The following is a description of a gene set: Genes predicted to be targets of miRBase v22 microRNA mmu_miR_129b_5p in miRDB v6.0 with MirTarget v4 prediction scores > 80 (high confidence targets). studied in species Mus musculus Mouse Gene Set: MIR_129B_5P from publication Chen Y, Wang X (PMID 31504780), and this is the list of marker genes: Acbd3, Frk, Pou2f2, Zfhx3, Ttc28, Gabrb2, Wnt3, Brpf1, Tfap2b, Bzw1, Megf9, Ctxn3, Vgll3, Med14, Tmem33, Nr2f6 (nuclear receptor subfamily 2, group F, member 6), Tmem158, Ephb1, Smarca4, Adipor2, Prdm16, Rab14, Lcorl, Pimreg, Zeb2, Onecut2, Arhgef9, Yipf4, Aak1, Maml1, Map2, Cxxc5, Myrip, Smad7, Hao2, Nhlh2, Mycl, G6pc1, Ppm1b, Zmym4, Abi3bp (NCBI Gene Id 360036), St6galnac5, Sgms1, Alcam, Me2, Kansl3, Ro60, Slc30a7, Ptbp3, Mdga2, Spats2 (NCBI Gene Id 72572), Mef2a, Gria2, Kcnb1, Myt1l, Il12b (interleukin 12b), Tshz1, Klf13, Bud23 (BUD23, rRNA methyltransferase and ribosome maturation factor), Gramd1c, Tnrc6c, Bcl11b, Lsm14a, Pigh, Tcf7l2, Plppr5, Setd7, Lingo2, Wac, Tshz3, Cpsf2, Ptchd4, Strn3, Bcl6, Tmtc4, Hnrnpc (heterogeneous nuclear ribonucleoprotein C), Dlk1, Nlk, Igf1r, Slc17a5, Bnc2, Spata2l, Ubl3, Rbfox1, Rbm27, Ppp3ca, Hipk2, Psg29, Sema3c, F13a1, Ensa (NCBI Gene Id 99644), Nhlh1, Tead1, B3galt1, Fry, St8sia3, Dtna, Lrrtm2, Cadm1, Dnajc7, Stxbp4, H2-M10.1, Rufy2, Kctd6, Arid3a, Cep43 (NCBI Gene Id 75296), Kdm2a, Bmp2, Adamts5, Cyfip1, Mapk8, Mpdz, Lias, Dnmt3a, Tnrc6b, Arf4, Pramel48, Pou3f2, Psapl1, Nxph1, Prkacb, Nus1 (NUS1 dehydrodolichyl diphosphate synthase subunit), Mdfic, Fndc3a, Cux1, Fbn2, Dkk2, Magi3, Slc25a3, Nalf1, Lrrc4c, Macroh2a2, Arid5a, Pik3ca, Plxna2, Pcdh19, Ahdc1, Slc22a22, Tmem38b, Cmip, Glcci1, Sp1, Pcdh17, Hoxc6, Gucy1a2, Cd2ap, Dclre1c, Slc4a1, Mblac2, Mpped2, Pramel60, Thsd7a, Fas, Cdh4, Pwwp2a, Gli2, Picalm, Echdc1, Col25a1, Elavl3, Elp4, Hoxa4, Grin2b, Satb1, Npas3, Scnn1g, Rbms3, Prlr, Olfm3, Tph1, Arhgap15, Nkx2-1, Otud5, Lhx2, Qrfprl, Caskin1, B3galt2, Mtf1, Ebf1, Sox11, Eif4e, Tbl1x, Zfp536, Dennd1b, Nfia, Btla, Chl1, Nfat5, Arhgap32, Pkn2, Kctd1, St7, Arid1b, Scn8a, Bicd1, Sf3a3, Nrp2, Zyg11b, Crebrf, Sertad2, Map3k2, Slc6a6, Tmem132c, Crim1 (NCBI Gene Id 50766), Klf6, Kcnv1, Pde4a, Anks1b, Mfsd14a, G3bp1